Given this list of marker genes Snx6, Ankrd27, Snx5, Vps35, Vps26a, here is a description of the gene set: species: Mus musculus A network of fine tubules in the vicinity of the Golgi complex and around the centriole. Mouse Gene Set: GOCC_TUBULAR_ENDOSOME